The following is a description of a gene set: Phase 0 is the rapid depolarisation phase in which electrical stimulation of a cell initiates events involving the influx and efflux of ions resulting in the production of a cell's action potential. The cell's excitation opens the closed, fast Na+ channel proteins, causing a large influx of Na+ creating a Na+ current (I<sub>Na+</sub>). This causes depolarisation of the cell then voltage-dependent L-type calcium channels (LTCCs) transport Ca2+ into excitable cells. The slope of phase 0 represents the maximum rate of potential change and differs in contractile and pacemaker cells. The potential in this phase changes from around -90mV to around +50mV (Park & Fishman 2011, Grant 2009). Reactome Pathway: Phase 0 - rapid depolarisation studied in species Homo sapiens part of: Cardiac conduction, and this is the list of marker genes: SCN1B, CACNG7, SCN3B, SCN11A (NCBI Gene Id 337933), FGF13, SCN1A, SCN4B, CAMK2B, CACNG4, CAMK2G, FGF11, FGF14, CACNA1C, CAMK2D, CAMK2A, SCN8A, CACNB2, SCN5A, CACNG6, SCN7A, SCN4A, SCN2A, CACNA2D2, SCN2B, CALM1, SCN3A, CACNB1, SCN9A, RANGRF, SCN10A, CACNG8, FGF12